The following is a description of a gene set: studied in species Homo sapiens Human Gene Set: HALLMARK_G2M_CHECKPOINT Genes involved in the G2/M checkpoint, as in progression through the cell division cycle. from publication Liberzon A, Birger C, Thorvaldsdóttir H, Ghandi M, Mesirov JP, Tamayo P (PMID 26771021), and this is the list of marker genes: PBK (NCBI Gene Id 55886), MAD2L1, KIF22, EFNA5, CDKN1B, UBE2S, RBM14, CDKN2C, SUV39H1, HNRNPU, CHAF1A, CCNB2, NEK2, NOTCH2 (notch receptor 2), HMGN2, NUMA1, KNL1, CKS1B, SMC2 (structural maintenance of chromosomes 2), UCK2, MCM2, BUB1, NSD2, KIF11, KIF4A, TGFB1, STMN1, KIF20B, PML, CTCF, SMARCC1, TPX2, HOXC10, TROAP, ORC6, MT2A, RPA2, KATNA1, KIF23, RACGAP1, E2F3, MCM3, MAPK14, SMAD3, ATF5, E2F1, ARID4A, CDC25A, KPNB1, SMC4, EXO1, PAFAH1B1, E2F4, FBXO5, G3BP1, LMNB1, POLA2, CDC7, NASP, DBF4, TRA2B, AMD1, RASAL2, CKS2, MNAT1, TFDP1, STAG1, SLC12A2, RAD21, CDK1, NUSAP1, PDS5B, CDC25B, CUL3, HMMR, CCNF, H2AZ2, ORC5, CUL5, EZH2, CDKN3, NDC80, MKI67, SLC7A1, HMGA1, SMC1A, SAP30, BCL3, RBL1, UBE2C, SQLE, INCENP, LBR, HMGB3, CDC6, FOXN3, TOP2A, H2AX, CBX1, SFPQ, CUL4A, PLK1, SLC38A1, XPO1, HNRNPD, NCL, MYBL2, TTK, GINS2, H2BC12, CDC45, LIG3, TOP1 (DNA topoisomerase I), MEIS2, SRSF10, FANCC, NUP98, NUP50, DDX39A, SLC7A5, CDK4, AURKA, EGF, STIL, ATRX, DKC1, CHMP1A, EWSR1, PRC1, DR1, CENPE, KIF2C, POLE, BUB3, CUL1, DTYMK, GSPT1, TACC3, PLK4, BRCA2, PURA, MYC, PTTG3P, CCNT1, CDC27, KMT5A, ABL1, RAD23B, MCM6, BIRC5, KIF15, UPF1, SRSF1, SS18, YTHDC1, E2F2, PRP4K, CENPA, ESPL1, DMD, MTF2, TENT4A, JPT1, MEIS1, HUS1 (HUS1 checkpoint clamp component), ILF3 (interleukin enhancer binding factor 3), HIF1A, CENPF, H2AZ1, TRAIP, CCND1, TMPO, CCNA2, RAD54L, MARCKS, MAP3K20, MCM5, AURKB, PTTG1, PRMT5, PRIM2, KIF5B, SRSF2, TLE3, CASP8AP2, SYNCRIP, WRN, SNRPD1, TNPO2, KPNA2, HSPA8, ODC1, ODF2, POLQ, BARD1, CDC20, RPS6KA5, CHEK1 (checkpoint kinase 1), NOLC1, HIRA